Given this list of marker genes CAMK2D, MYH7, KCNE5, CAV1, MIR448, GPD1L, SCN11A, JUP, KCNJ8 (potassium inwardly rectifying channel subfamily J member 8), ACTA2, MYL6B (myosin light chain 6B), SCN1B, MYO1C, MYO1D, CACNA1G, ACTC1, FGF12, TPM1, MYLK2, FRMD6, SUMO1, MYO7B (myosin VIIB), PKP2, TRPM4, NOS1AP (NCBI Gene Id 9722), SLC9A1, PIK3CA, SHTN1, SCN2A, MYO5A, CACNA1C, MYO6, MYH3, PARVA, SCN9A (sodium voltage-gated channel alpha subunit 9), WAS, MYH10, SGCD, MYO9B, TTN, MYH4, ATP1A1, SCN4A, CTNNA3 (catenin alpha 3), PDPN, ACTN4, MYBPC3 (NCBI Gene Id 4607), ATP2A2, MYO1A, SCN4B, FNBP1L, VIL1, MYH14 (NCBI Gene Id 79784), MYH6, DLG1, LIMCH1, MIR133A1, GJA5, CCDC88C, DSG2, KCNE1, MYL11, SYNE2, KCNE3, NUP155, GSN, STRIT1, MYH9, SCN5A, EPB41L5, MYH7B, TCAP, GATA4, WASF2 (NCBI Gene Id 10163), KCNA5, PLN, CACNA1D, QKI, KCNE4, SCN2B, MYO1H, CACNB2, TNNT2, ATP1A2 (NCBI Gene Id 93186), KCNQ1, C10orf71 (chromosome 10 open reading frame 71), FGF13, ATP2A1, SCN1A, RANGRF, ADCY10, KCNN2, KCND3, MYH8, KCNE2, ROCK1, ABCC9, EPDR1, SUN2 (Sad1 and UNC84 domain containing 2), PDE4B (NCBI Gene Id 5142), SCN10A, TNNC1 (troponin C1, slow skeletal and cardiac type), KCNJ3, EMP2, PDE4D, HCN4, KCNJ2, RYR2, NOS1 (NCBI Gene Id 4842), FLNA, MYO19, BIN1, MYL6, SCN7A, AKAP9, CACNA2D1, ANK2, SNTA1, NEDD4L, WIPF1, GJA1, WASL, RNF207, MYH2, ADORA1 (NCBI Gene Id 134), LUZP1, SCN3B, MYO1B, DSP, SRI, DSC2 (desmocollin 2), CASQ2, KCNH2, CAV3, STC1, GJC1, SCN8A, MIR328, MYL1, MIR1-1, ZEB2, TNNI3, MYO1G, KCNJ5, SCN3A, MYO7A, here is a description of the gene set: Movement of organelles or other particles along actin filaments, or sliding of actin filaments past each other, mediated by motor proteins. Human Gene Set: GOBP_ACTIN_FILAMENT_BASED_MOVEMENT studied in species Homo sapiens